Given this list of marker genes SPATA31C1, SPC25, HSD17B12, UACA, AEBP2, UPF3A, GNAQ, RPRM, RAB14, here is a description of the gene set: Genes predicted to be targets of miRBase v22 microRNA hsa-miR-1537-3p in miRDB v6.0 with MirTarget v4 prediction scores > 80 (high confidence targets). from publication Chen Y, Wang X (PMID 31504780) Human Gene Set: MIR1537_3P species: Homo sapiens